Given this list of marker genes Fyn, here is a description of the gene set: This event has been computationally inferred from an event that has been demonstrated in another species.<p>The inference is based on the homology mapping from PANTHER. Briefly, reactions for which all involved PhysicalEntities (in input, output and catalyst) have a mapped orthologue/paralogue (for complexes at least 75% of components must have a mapping) are inferred to the other species. part of: Hemostasis electronically inferred by orthology from the curated human pathway Reactome Pathway: Platelet Adhesion to exposed collagen studied in species Mus musculus